Given this list of marker genes PM20D1, here is a description of the gene set: part of: Mitochondrial Uncoupling Extracellular PM20D1 (N-fatty-acyl-amino acid synthase/hydrolase PM20D1) catalyzes the reversible condensation of L-phenylalanine (L-phe) and oleate ((9Z)-octadecenoate) to form oleoyl-phe (N-(9Z-octadecenoyl)-L-phenylalanine) and water. In addition to the condensation of phe with oleate ((9Z)-octadecenoate) annotated here, purified human PM20D1 protein in vitro can catalyze the condensation of leucine and isoleucine with oleate and with other long-chain unsaturated fatty acids including arachidonate, with lower efficiencies. Although the reverse (hydrolysis) direction of this reaction is thermodynamically favored, expression of PM20D1 protein in mice or in cultured cells was associated with elevated levels of oleoyl-phe in serum and culture media, respectively. Treatment of cultured mouse brown adipose tissue adipocytes and of isolated mitochondria with oleoyl-phe induced uncoupled respiration independently of UCP1 (uncoupling protein 1). Photolabeling studies of isolated mitochondria identified the ADP/ATP symporters SLC25A4 and SLC25A5 as possible targets of oleoyl-phe. Consistent with these observations, expression of PM20D1 and elevated blood levels of oleoyl-phe in mice were associated with increased energy expenditure and improved glucose homeostasis. These results suggest a physiological role for PM20D1 and its condensation reaction product in thermogenesis and raise the possibility that oleoyl-phe and related molecules might have a clinical role in treatment of obesity. Reactome Pathway: Oleoyl-phe metabolism species: Homo sapiens